The following is a description of a gene set: Mouse Gene Set: GOBP_SINGLE_FERTILIZATION species: Mus musculus The union of male and female gametes to form a zygote., and this is the list of marker genes: Zp3r, Garin2, Irag2, Spesp1, Iftap, Lyzl6, Slxl1, Ar, Cntln, Hyal5, Adam1b, Itga3, 4930451I11Rik, Cct8, Rnase10, Adam1a, Tarbp2, Fcrl5, Sppl2c, Pkdrej, Spag8, Smcp, Glra1, B4galt1, Spaca4, Garin4, Lyzl4, Poc1b, Hexb, H3f3a, Ccdc159 (NCBI Gene Id 67119), Hoxd11, Syt6, Wt1, Syt8, Trpc3, Foxl2 (NCBI Gene Id 26927), Dcst2, Lhfpl2, Cfap70, Cct3, Myh9, Garin1b (NCBI Gene Id 330277), Dcst1, Unc13b, Umodl1, Hspa1l, Spink13, Tmprss12, Izumo1r, Cd9, Plb1, Zpbp2, Spink1, Sec23ip, Wdr54, Mcidas, Hoxa9, Frey1, Izumo1, Rims1, Actl7a, Folr2, Ppp3cc, Crkl, Pmis2, Hoxd9, Cct7, Eqtn, Ubap2l, Zan, Stxbp1, Spaca3, Adam5, Crisp4, Cylc1, Cct4, Snu13 (SNU13 homolog, small nuclear ribonucleoprotein (U4/U6.U5)), Gnpda1, Hspa1b (NCBI Gene Id 15511), Npm2, Fam170b, Bsph1, Slc22a16, Tpst2, Spam1, Leat1, Kmt2c, Hps1, Prnd, Smad4, Tnp2, Ap3b1, Lypd4, Cylc2, Ccdc87, Zp2, Trpc7, Adam18, Adam24, Llcfc1, Zpbp (zona pellucida binding protein), Ube3a, Plcd4, Odad3, Aldoa, Clgn, Wbp2nl, Park7, Adcy3, Ccno (NCBI Gene Id 97901), Tcp1, Itpr1, Col6a1, Cfap57, Sly, Rab3a, Iqcf1, Slx, Lcn6, Cfap119, Ly6k, Pla2g10 (NCBI Gene Id 26969), Stx2, Pithd1, Trpc2, Garin5a, Spata46, Abhd2, Hoxa10, Adam3, Wdr48, Iqcn, Cct6a, Zp3, Spaca5, Lrriq1, Cast, Cd46, Ovgp1, Cct2 (chaperonin containing TCP1 subunit 2), Bbof1, Hoxd10, Plcb1, Cecr2, Camk2b, Tmem95, Nlrp5, Plcz1, Ccdc136, Hyal3, Hvcn1, Adam32, Glrb, Prss55, Ccdc146, C2cd6, Trim36, Slirp, Prss37, H3f3b, Cacna1h, Fetub, Tex101 (NCBI Gene Id 75446), Spa17, Antxr2, T, Zp1, Ash1l, Kdm5b, H1f6, Cct5, Acr, Adam2, Atp8b3, Cfap52, Spaca6, Plat, Drc1, Gm773, Garin5b, Fsip1, Vdac2, Tmem81 (NCBI Gene Id 98373), Fbxo24, Garin3, Wee2, Pcsk4, Glipr1l1, Slc9b1, Iqch, Actl9, Spaca7, Catsper1, Npr2, Lrrc46, Trpc6, Arsa (NCBI Gene Id 11883), Astl, Ppp3r2, Hoxa11, Mfge8, Spag1, Rabl2, Gmnc, Folr1, Dkkl1